The following is a description of a gene set: Human Gene Set: GSE40274_CTRL_VS_IRF4_TRANSDUCED_ACTIVATED_CD4_TCELL_DN studied in species Homo sapiens Genes down-regulated in CD4 T conv: control versus over-expression of IRF4. The transcription factor FoxP3 partakes dominantly in the specification and function of FoxP3+ CD4+ T regulatory cells (Tregs), but is neither strictly necessary nor sufficient to determine the characteristic Treg transcriptional signature. Computational network inference and experimental testing assessed the contribution of several other transcription factors (TFs). Enforced expression of Helios or Xbp1 elicited specific signatures, but Eos, Irf4, Satb1, Lef1 and Gata1 elicited exactly the same outcome, synergizing with FoxP3 to activate most of the Treg signature, including key TFs, and enhancing FoxP3 occupancy at its genomic targets. Conversely, the Treg signature was robust to inactivation of any single cofactor. A redundant genetic switch thus locks-in the Treg phenotype, a model which accounts for several aspects of Treg physiology, differentiation and stability. from publication Fu W, Ergun A, Lu T, Hill JA, Haxhinasto S, Fassett MS, Gazit R, Adoro S, Glimcher L, Chan S, Kastner P, Rossi D, Collins JJ, Mathis D, Benoist C (PMID 22961053), and this is the list of marker genes: REM2, MAFA, UBXN4, TCP1, PDP1, ATP6V0D1, PVR, IRF2BP2, SMOX, ZBTB25, APOBEC2, FGFRL1, GPSM1, PLSCR2, PRF1, WNK1, PPP1R10 (NCBI Gene Id 5514), ARRDC3, KLF11, GLYATL3 (NCBI Gene Id 389396), CYP26A1, MANEA, PRKX, SLC25A38, AGPAT5, IRAK1BP1, BATF, IGF2R, TENT5C, APRT, ROM1, NRBP1, PGM1, UBQLN1, SLC3A2, MED21, UMPS, UBE2S, TBC1D15, SPAG9, FAM167A, BAMBI, FBXO6, IFT140, CCDC9, PRRG4, CRY1, SEC24A, SNX18, PNPO, EMD, PPP1R16B, CCT5, BHLHE40, KLF4, CTNNAL1, CWC25, MED10, FZD5, NT5DC3, OSGIN2, DENND4A, PSKH1, VPS18, SPATA4, MAP3K8 (NCBI Gene Id 8040), BSPRY, B4GALT1, DEGS1, SATB1, MRPL54, MREG, IL21R, HCCS, YRDC, GPSM2, MAP3K1, ITK, NT5C2, UBC, TAF4B, CCR4, KCTD10, SGSM1, NXPH4, MOXD2P, FKBP4, UNG, ZFP64, HIVEP3, SLC49A4 (solute carrier family 49 member 4), RHEB, MIR17, FAM76A, B4GALT5, HSPA4L, NCF1, DOT1L, NR1D2, TGIF1, GNB5, CDS1, IL3RA, AHSA1, PRKAR1A, TRIP10, CST9, OTUD1, PTGS2, DNAJB6, EIF2S2, LRRC32, TNFRSF9, TBC1D30, TMEM17, UNC45A, REL, TIMM23, OPA3, RNF125, DDX54, CD274, EXTL2, ZSWIM4, OASL, TAGAP (T cell activation RhoGTPase activating protein), PLK3, SH2D2A, MORF4L2, F3, MIR668, MCM2, CD93, SELENOK, SLC43A3, SULT2B1, BCL2L13, KIF18A, RYBP, INSIG1, SOCS7, FOXE3, PSD, CCT6A, FOS, BSDC1, PCDHB9, TUFT1, BOK, KLF6, ZFAND2B, NUDT4, LMBR1L, CDR2, MAGOH (mago homolog, exon junction complex subunit), SIK1, ZMAT4, SIDT2, GPR137C, DUSP18, RASGEF1B, TMEM120B, MIA, ODC1, KBTBD13, CLEC4E